The following is a description of a gene set: studied in species Homo sapiens Human Gene Set: GOCC_U5_SNRNP A ribonucleoprotein complex that contains small nuclear RNA U5, a heptameric ring of Sm proteins, as well as several proteins that are unique to the U5 snRNP, most of which remain associated with the U5 snRNA both while the U5 snRNP is free or assembled into a series of spliceosomal complexes., and this is the list of marker genes: SNRPG, PRPF6, TXNL4B, RNU5D-1, RNU5A-1, SNRPN, RNU5E-1, RNU5F-1, TXNL4A, SNRNP40, SNRPD3, SNRPGP15, SNRPE, SNRPD1, SNRPD2, DDX23, RNU5B-1, SNRPB, PRPF18, CD2BP2, TSSC4, SNRNP200, AAR2, SNRPF, PRPF8